The following is a description of a gene set: Any apoptotic process in a keratinocyte. A keratinocyte is an epidermal cell which synthesizes keratin and undergoes a characteristic change as it moves upward from the basal layers of the epidermis to the cornified (horny) layer of the skin. Mouse Gene Set: GOBP_KERATINOCYTE_APOPTOTIC_PROCESS species: Mus musculus, and this is the list of marker genes: Pias4, Zfp36l1, Zfp36, Gsn, Serpinb13, Trim32, Sav1, Sfrp4